Given this list of marker genes Gm13194, Mir466g, 4930551O13Rik, Gm10851, Mir669e, Sephs1, Gm13193, Gm34768, Mir669k, Mir467d, Pfkfb3, Mir669a-10, Gm13192, Gm13388, Gm18547, Mir466c-2, D930036K23Rik, C1ql3, Mir297b, Gm13264, 1700061F12Rik, Gm13291, Gm13391, Ucma, Gm13294, Ankrd16 (ankyrin repeat domain 16), Optn, Il2ra, Gm13216, Itih5, Mir466d, Proser2, Mir669o, Mir669j, Mir467a-9, Gata3os, Gm38171 (predicted gene, 38171), Nmt2, Gm13196, Olah, Stamos, Celf2, Cubn, Gm13179, Gm2639, Mir467c, Gm13267, Bend7, Sec61a2, Rpp38, Fam171a1, Upf2, Stam (signal transducing adaptor molecule (SH3 domain and ITAM motif) 1), Hspa14, Itga8, Kin, Nudt5, Echdc3, Gm10115, Mir466l, Mir669g, Gm13182, Mir669b, Phyh, Msantd7, Gm13270, Gm23877, Mir467e, Gm13211, Usp6nl, Gm13384, Gm13297, Gm13260, Mir297a-2, Gm13296, Gm13310, Mir466f-2, Meig1, Hacd1, Gm13219, Ccdc3, Frmd4a, Camk1d, Fbh1, Mir466b-8, Gm22005, Gm13293, Mir466o, Trdmt1, Mir297a-3, Mir669c, Gm23691, Mir466f-1, Mir466f-3, Mir669d-2, Mir466p, Rbm17, Dclre1c, A230108P19Rik, Mir669f, 1700080N15Rik, Mir669i, Gm13199, Mindy3, Acbd7, Il15ra, Atp5f1c, Gm13181, Mir297a-4, Dhtkd1, Mir669m-2 (microRNA 669m-2), 8030442B05Rik, Cdnf, Gm13383, Sfmbt2, Gm13187, Mir669l, Gm13261 (NCBI Gene Id 102633824), Dreg1, Mir669a-3, Gata3, Pter, Mir669m-1 (NCBI Gene Id 100316701), Fam107b, Gm10862, Prkcq, Mir669d, Mir466, Gm13263, 1700014B07Rik, Gm13198, Gm10855, Gm23608, Mir466m, Gm13188, Mir297c, Gm13292, Itih2, Mir669h, Gm13254, Gm24340, Gm26478, Suv39h2, Gm13186, Gm13180, Mir466h, Gm10857, Gm13262, E030013I19Rik (RIKEN cDNA E030013I19 gene), St8sia6, Mir467a-7, Vim, Mcm10, 4933403L11Rik, Cdc123, Mir466b-3, Gata3un, Mir466c-3, Taf3, Gm13176, C630004M23Rik, Gm13321, Mir669a-2, Rsu1, Gm23118, Mir466n, Prpf18, Mir669a-6, Gm13217, Gm13197, here is a description of the gene set: Mouse Gene Set: chr2A1 studied in species Mus musculus